The following is a description of a gene set: Any process that reduces or removes the toxicity of inorganic compounds. These include transport of such compounds away from sensitive areas and to compartments or complexes whose purpose is sequestration of inorganic compounds. studied in species Homo sapiens Human Gene Set: GOBP_DETOXIFICATION_OF_INORGANIC_COMPOUND, and this is the list of marker genes: MT2A, MT1H, MT4, ATP7A, SLC11A1, MT1B, MT1M, MT1F, MT1DP, ABCB6 (NCBI Gene Id 541461), MT1HL1, TXN, CAT, MT1A, SLC39A8, MT1X, PARK7, SLC30A10, MT1G, MUC2, MT3, MT1E, SLC30A1